The following is a description of a gene set: Human Gene Set: GOBP_POTASSIUM_ION_IMPORT_ACROSS_PLASMA_MEMBRANE species: Homo sapiens The directed movement of potassium ions from outside of a cell, across the plasma membrane and into the cytosol., and this is the list of marker genes: ANK2, KCNJ10, ATP4B, ABCC9, ATP1A2, ATP1B2, SLC12A5, ATP1B3, KCNJ11, KCNJ9, KCNJ12, ATP1B1, KCNJ13, ATP4A, HCN3, KCNJ1, FXYD2, SLC12A7, KCNK9, KCNJ16, KCNQ1, HCN4, KCNJ4, SLC12A4, ATP1A4, KCNH2 (potassium voltage-gated channel subfamily H member 2), STK39, KCNJ3, KCNJ8, SLC12A6, KCNJ5, SLC12A2, MIR26A1, ATP1A3, SLC12A3, SLC12A8, MIR103A1, KCNE2, HCN1, KCNJ18, KCNJ6, HCN2, DLG1, KCNJ14, ATP12A, KCNK5, KCNJ15, MIR30D, ATP1A1, SLC12A1, ABCC8, KCNJ2